The following is a description of a gene set: Interleukin-33 (IL-33) is elevated in afflicted tissues of patients with mast cell-dependent chronic allergic diseases. Based on its acute effects on mouse mast cells (MCs), IL-33 is thought to play a role in the pathogenesis of allergic disease through MC activation. However, the manifestations of chronic IL-33 exposure on human MC function, which best reflect the conditions associated with chronic allergic disease, are unknown. We now find that long-term exposure of human and mouse MCs to IL-33 results in a substantial reduction of MC activation in response to antigen. This reduction required >72 h exposure to IL-33 for onset and 1-2 wk for reversion following IL-33 removal. This hypo-responsive phenotype was determined to be a consequence of MyD88-dependent attenuation of signaling processes necessary for MC activation including antigen-mediated calcium mobilization and cytoskeletal reorganization; potentially as a consequence of down-regulation of the expression of PLCg1 and Hck. These findings suggest that IL-33 may play a protective, rather than a causative role in MC activation under chronic conditions and, furthermore, reveal regulated plasticity in the MC activation phenotype. The ability to down-regulate MC activation in this manner may provide alternative approaches for treatment of MC-driven disease. species: Homo sapiens Human Gene Set: GSE39382_IL3_VS_IL3_IL33_TREATED_MAST_CELL_DN from publication Jung MY, Smrž D, Desai A, Bandara G, Ito T, Iwaki S, Kang JH, Andrade MV, Hilderbrand SC, Brown JM, Beaven MA, Metcalfe DD, Gilfillan AM (PMID 23248261) Genes down-regulated in bone marrow-derived mast cells treated with IL3: control versus IL33., and this is the list of marker genes: ICOS, AP3S2, CDH8 (cadherin 8), PPP1R1A, DDX60 (NCBI Gene Id 55601), PVR, ENY2, C5orf15, CBX4, CASP1, PTPRU, GCH1, AQP3, IGFBP4, KCNN4, DYNLT1, TRIM21, CLSTN3, SGCB, STOML1, EIF6, MN1, TSFM, FUBP1 (far upstream element binding protein 1), ID2, RCN1, FCHSD2, TAGLN2, PML, ZBTB17, SPDL1, MAP3K9, GUCY1A1, CENPJ, IGF2BP2, SCO2 (synthesis of cytochrome C oxidase 2), LIMK2, PDGFRA, HSPA4, DMAC2L, CEP15, SLC39A8, TRPC4AP, DNAJC15, MIA3, UBE2NL, OAS1, SBNO2, MTF1, SLC31A2, MX1, CLEC2D, MCL1, PLAAT4, CMTR1, ABRAXAS2, TARP, PRG4, SPATS2L, APOL3, TAB2, RBMS2, DOP1A, MYO10, TDRD7, TMEM158, B3GNT4, NETO2, USP18, HERC6, COA1, GRSF1, TBC1D9, CSRNP2, MT3, KIFAP3, IL4R, MAP3K13, WTAP, CRISP1, MYH11, RDX, CAMK1G, RHOG, LMNB1, TBL1Y, PCNX1, G0S2, BIRC3, IL1RN (NCBI Gene Id 3557), ICAM1, GAD1, DIPK1A, SSTR2, POMP (NCBI Gene Id 51371), INSM1, ELF4, PPP3CC, TES, ACHE, SNIP1, STX11, ADIRF, APOL1, TRGV5, HERC5, IRF8 (interferon regulatory factor 8), XPNPEP1, FSTL3, DNAJB5, CTC1, TXN, STEAP3, CD2BP2, KDM4D, SNX10, TRIM22, WASL, CD47, NAMPT, TNIP1, C1R, KLF5, IRF7, DEPP1, RIPK2, TMEM132A (NCBI Gene Id 54972), PIGB, NFKB2, ACOT9, GPR153, STK17B, SLC25A28, GTPBP1, TMEM131, TNFAIP6 (TNF alpha induced protein 6), GART, GADD45G, NR4A3, PPP1R16B, TARS1, CFLAR, PFKFB3, RELA, PLAC8, TUBB3, TNFAIP2, SLC1A2, IFIT2, JAK2, ISG15, LARP1, OAS3, OR7E36P, CUL1, DRAM1, PRKCQ, DESI1, MX2, ABTB2, BATF3, UBB, NINJ1, CTNNBL1, TRADD, ABI1, ELMO2, TNFAIP3, IFITM3, RFTN1, CSTF3, VAC14, KIR2DS5, PGM3, ETV7, BPNT2, POTEKP, MIA, BAK1, WDR55, TSKU, AQP9, IRF1, HESX1, MSC, AK4, SP110, ATP2B4 (NCBI Gene Id 54594), DIAPH1, PSMB10, CYLD, IFNG, LY6E, CKAP4, TYMP, PKIG, BCL2L14, C1orf21, LAMB3, NFKB1